The following is a description of a gene set: Any anomaly of the progression of electrical impulses through the heart. species: Homo sapiens Human Gene Set: HP_CARDIAC_CONDUCTION_ABNORMALITY Cardiac conduction abnormality, and this is the list of marker genes: CDC45, GPX4, SCN1B, MT-CO2, GYG1, MYL2, HCN4, AGXT, SCN5A, CACNA2D1, LARS2, CACNB2, DOHH, EP300, GNB5, TRDN, MYH6, NPPA, PRKAG2, TBX20, CAPNS1, RAF1, MT-ND2, SCN2B, SDHAF1, FHL1, ACTA1, ACADVL, SYNE2, PLEC, GNB2, GATA6, GNAI2, PTPN11, CITED2, TTR, MT-ATP6, RNASEH1, DNMT3B, ABCC9, MT-TQ, KCNE3, DEF6, CNBP, KCNJ2, CLCN1, RANGRF, NKX2-5, KCNH2, MT-TH, KCNK3, CACNA1C, MT-ATP8, DUX4L1, GLA, SDHD, RRM2B, TNNC1, DYSF, MT-ND5, LDB3, LRP1, SCN10A, MT-TS2, SEMA3A, MT-TL1, KCNJ8, TRPM4 (NCBI Gene Id 8184), CASQ2, KCNQ1, CACNA1A, ACTC1, MT-TF, SYNE1, SGO1, SMCHD1, LAMP2, PSEN2, MT-TV, BTNL2, RMRP, TNNT2, POLG2, SLC4A3, MT-TW, MT-CYB (NCBI Gene Id 4519), GPD1L, GPC4, CREBBP, EXOSC5, TMEM43, MYPN, SCN4B, CTNNA3, FLNC, GPC3, TBX5, DSG2, CALM2, MT-TK, LMOD2, POMT2, MYOZ2, MT-ND1, TLL1, PRKG2, EMD, SLMAP, KCNJ18, MT-ND4, AKAP9 (A-kinase anchoring protein 9), DMPK, CPT2, SELENON, SDHA, ATP1A2, PEX7, CALM1, MMP2, CDH2, BANF1, VEZF1, MMP14, PKP2, MYL4, FRG1, BVES, RYR2, MT-CO3, GABRA3, TNNI3K, PIGU, SCNN1A, BRAF, JUP, GRIN1, ATP1A3, GJA5, KCND3, ATP6V1E1, CALM3, MYBPC3, MT-ND3, SCN3B, SLC25A20, CACNA1S, KCNE5, PSEN1, LEMD2 (NCBI Gene Id 221496), MYH7, ACTN2, DTNA, TTN, MT-ND6, DUX4, MT-CO1, DES, SLC1A3, CACNA1D, GATA4, KCNJ5, PHYH, SDHB, LMNA, PPP1CB, HLA-DRB1